The following is a description of a gene set: studied in species Homo sapiens Human Gene Set: GOBP_CHONDROCYTE_PROLIFERATION The multiplication or reproduction of chondrocytes by cell division, resulting in the expansion of their population. A chondrocyte is a polymorphic cell that forms cartilage., and this is the list of marker genes: DDR2, MUSTN1, LTF, SIRT6, ERRFI1, BMPR1B, SMAD7, MMP14, STC1, MMP16, FGFR3, LEF1, COMP, IHH, FOSL2, CCN2, EXT1, SIX2, PBXIP1, SOX9, BMPR2, SLC26A2, MIR21, CCN3, HMGA2 (high mobility group AT-hook 2), NPR2